The following is a description of a gene set: species: Homo sapiens Human Gene Set: GOCC_GRANULAR_COMPONENT A structure found in the nucleolus, which contains nearly completed preribosomal particles destined for the cytoplasm., and this is the list of marker genes: CARF, SURF6, NPM1 (nucleophosmin 1), CLEC3B, FBL, CDKN2AIP, RRP1B